The following is a description of a gene set: The process whose specific outcome is the progression of the His-Purkinje system over time, from its formation to the mature structure. The His-Purkinje system receives signals from the AV node and is composed of the fibers that regulate cardiac muscle contraction in the ventricles. Human Gene Set: GOBP_HIS_PURKINJE_SYSTEM_DEVELOPMENT studied in species Homo sapiens, and this is the list of marker genes: HOPX, ID2, TBX5, TBX3, NKX2-5, IRX3, DSG2